Given this list of marker genes Arnt, Hsp90ab1, Ahr, Ahrr, Bmal2, Aip, Bmal1, Arnt2 (NCBI Gene Id 11864), here is a description of the gene set: Mouse Gene Set: GOCC_ARYL_HYDROCARBON_RECEPTOR_COMPLEX A protein complex that acts as an aryl hydrocarbon (Ah) receptor. Cytosolic and nuclear Ah receptor complexes have different subunit composition, but both contain the ligand-binding subunit AhR. studied in species Mus musculus